The following is a description of a gene set: Human Gene Set: HP_POLYCLONAL_ELEVATION_OF_IGM Polyclonal elevation of IgM A heterogeneous increase in IgM immunoglobulins characterized by a diffuse band on serum electrophoresis. studied in species Homo sapiens, and this is the list of marker genes: TCF4, SEMA4D, GPR35, MST1, MYD88, KLHDC8B (kelch domain containing 8B)